The following is a description of a gene set: studied in species Homo sapiens Human Gene Set: HP_POLYMICROGYRIA Polymicrogyria Polymicrogyria is a congenital malformation of the cerebral cortex characterized by abnormal cortical layering (lamination) and an excessive number of small gyri (folds)., and this is the list of marker genes: TRRAP, ATP1A2, WT1, MAGEL2, HSD17B4, CCDC88A, SNRPN, TUBA1A, TBC1D24, DLL1, TMEM218, TUBB3, CRPPA, STIL, CPT2, SF3B4, TOGARAM1, FKRP, AKT3, FH, CEP120, ATP6V0A2, KIF5C, ERCC1, SNAP29, NODAL, DHX37, LAGE3, TMTC3, SIN3A, COL3A1 (NCBI Gene Id 1281), POLR3A, TBC1D20, TMEM67, SMO, CEP41, COL4A1, INPP5E, TP53RK, ADGRG1, FIG4, GPHN, OCLN (NCBI Gene Id 4950), ACTB, DHCR24, SON, KIAA0586, TRMT10C, TMEM237, PEX3, KATNIP, MBOAT7, MICU1, FGF8, NPRL2 (NPR2 like, GATOR1 complex subunit), ODC1, CSPP1, SHMT2, FBXO28, CILK1, RTTN, DEPDC5, B4GAT1, SHH, GMPPB, RECQL4, SIX3, PEX5, SLC5A6, KIF21A, PAX6, TMX2, ESAM, KIFBP, WDR62, SCN3A (sodium voltage-gated channel alpha subunit 3), GRIN1, RAB3GAP2, CRIPTO, NDN, PEX16, ARHGAP31, PEX11B, RAB3GAP1, PEX6, SRPX2, GAS1, GPSM2, ATN1, TCTN1, ZNHIT3, TCTN3, PEX10, PIK3R2, ARHGEF9, NPRL3, PIGB, EML1, PPFIBP1, TUBB2B, TUBB, FKTN, PEX1, POMK, SRD5A3, GNB1 (NCBI Gene Id 87729), VPS4A, ARMC9 (armadillo repeat containing 9), CCND2, GLI2, NANS, FBXL4 (F-box and leucine rich repeat protein 4), HYLS1, B9D2, USP18, RAC1, PEX12, COL4A2, DAG1, PTCH1, MAP1B, ATP6V1A, LONP1, TUFM (NCBI Gene Id 7284), ROBO1, KIAA0753, BICD2, LARGE1, POMT1, COL18A1, TCTN2, ZEB2, PEX14, FOXH1, AHI1, DOCK6, PEX13, CPLANE1, RNU4ATAC, PTEN, ERMARD, PHOX2A, PI4KA, CBY1, MTOR, PIK3CA, PDHA1, SUFU, RRAGC, TUBA8, ATP6V1E1, EIF2AK2, DYNC1H1, SUZ12, MKS1, PDE6D, ARL13B, COL25A1, CEP104, POMGNT2, IFT74, PEX26, OCA2, RPGRIP1L, B9D1, PEX2, NEDD4L, B3GALNT2, MAN2C1, MAPK8IP3, POMGNT1, PIBF1, NSDHL, PEX19, ATP6V1B2, RAB18, DISP1, IBA57, POMT2, NPHP1, RXYLT1 (ribitol xylosyltransferase 1), TGIF1, EOMES, ARL3, LAMC3, KLHL15, FLVCR2, ATP1A3, KAT5, BMPER, PPP1R12A, KIF26A, OFD1, KATNB1, MYCN, NAA60, ZIC2, ACTG1, FDFT1, CUL4B, CDON, C2CD3, MECP2, MN1